The following is a description of a gene set: studied in species Homo sapiens Human Gene Set: MIR6838_5P from publication Chen Y, Wang X (PMID 31504780) Genes predicted to be targets of miRBase v22 microRNA hsa-miR-6838-5p in miRDB v6.0 with MirTarget v4 prediction scores > 80 (high confidence targets)., and this is the list of marker genes: KRTAP4-6, MAP3K13, UNC5D, MED26, SLC13A3, KCNG4, KIF23 (kinesin family member 23), DCP1A, DDX3X, LITAF, ZC2HC1A, VPS33B (VPS33B late endosome and lysosome associated), BCL2L2, RPS6KA3, CPD, SUCO, CAPRIN1, NHLRC2, LYPLA2, SEMA3A, ZBTB39, IPO7, GALNT13, ZCCHC3, SYT3, IVNS1ABP, OGT, CSRNP1, TLK1, TLL1, ZFHX3, FAM91A1, LURAP1L, RS1, COBLL1, PPT2, AGO1, ARIH1, ENAH, HOXA10, MYEF2, APLN, ROCK2, RPS6KA6, MAMSTR, DDX3Y, WEE1, SLC39A10, P3H2, MFN2 (NCBI Gene Id 9927), SPRED1, SEH1L, TAB3, SSTR3 (NCBI Gene Id 6753), ZNRF3, ZNHIT6, CPEB3, SPTBN2, RAB9A, SPRYD3, SOX6, C1QL3, CDK17, IGF2R, MEX3C, GCC2, MNT, ZNF449, ZFHX4, GLS2, TMC7, TENM2, STK33, PARVA, NRN1, CSDE1, SCN8A, PLAG1, RFX3, PAFAH1B1, RSPO3, EDA, MASP1, GNAT1, NSMF, HERC6, ELL (NCBI Gene Id 84205), NUFIP2, PHF19, INSR, SRPRA, ABHD2, TUBA4A, MYO5A, SLC2A14, ZSCAN31, PTPN3, CD47, AK4, SCOC, WNT7A, JARID2, SLC20A2, SMIM13, NR2C2, RBM6, RICTOR, CPSF7, FBXL20, TCAIM, DMPK, CASK, KRTAP11-1, GPR63, ATG13, FAM89A, RAB11FIP2, USP44, DEPDC4, DYRK1B, USP31, PLXNC1, KANK1, CFAP45, LRIG1, PPM1E, RECK, TMEM268, SNX16, AMOT, SNRPB2, UBFD1, JPH3, ANKRD46, CDCA4, SREK1, CDC42SE2, ABTB2, SNTB2 (syntrophin beta 2), CCNJL (NCBI Gene Id 79616), CLUH (NCBI Gene Id 23277), OMG, TNFSF13B, MKX, LAMC1, ARMCX2, ISLR, SLC36A1, KIF5C, PRDM4, IKBKB, ARL3, ATF6, RNF217, SLC11A2, PAPPA, ARHGAP12 (NCBI Gene Id 94134), DENND1B, G2E3, IFT74, ARHGAP32, SLC35G1 (solute carrier family 35 member G1), CACNA2D1, KCNN4, PTH, MOB3B, PAG1, ATXN7L3, TMCC1, NCS1, PPP6R3, MAP7, MYLK, CPEB2, SEMA5B, TFAP2A, PIP4P1 (phosphatidylinositol-4,5-bisphosphate 4-phosphatase 1), STXBP3, SYNJ1, SYNRG, MEOX2, ZBTB34, DRD1, HTR2A, MYT1L, CCNT1, PTPRR, SALL1, NF1, EPHB2, RASGEF1B, LRIG2, SHOC2, FAM133B, GPATCH8, RREB1, SOCS6, HEPHL1 (hephaestin like 1), RASSF8, BTG2, HSPG2, CCNE1, CDK5R1, FBXW7, HELZ, GPN1, USP3, UBE4A, PPP1R11 (NCBI Gene Id 9160), EPHA7, CD2AP, CYP2S1, CD80, AVL9, ANKUB1, SAMD10, EXOC3L2, PLPP1, ZMAT3, NRBP1, MTFR1L, TTC14, ACVR2B, POU2F1, DYNC1LI2, ARFGAP2, AHCYL2, STRADB, CACNA1E, ASH1L, CYP26B1, ZC3H13, CLCN4, SUZ12, AKT3, NOB1, PLXNA4, SGK1, FGF2, PEDS1-UBE2V1, PPM1A, TARBP2, BCL11B, HIGD1A, RELN, ZNF622 (zinc finger protein 622), CACUL1, PLRG1, AMOTL1, C2orf42, CLOCK, SLC9A6, LAMP3, ANO3, EZH1, PCMT1, MAP2K1, FASN (fatty acid synthase), CMPK1, TGIF2, TMEM154, BZW1, WNK3, FOXK1, CEP55, CDC27, DNAJB4 (DnaJ heat shock protein family (Hsp40) member B4), KIF3B, ZNRF2, TRIM66, CDC37L1, MOB4, MYO5B, HSPA4L (NCBI Gene Id 22824), AMMECR1, GFAP, WWC1, RBM24, HIPK2, FGF7, ST7L, ZCCHC2, TGFBR3, SERBP1, RASEF, ARHGDIA, SLC25A37, KDSR, VTI1B, HMGA1, XPO7, ATXN7L1, TMEM178B, ZNF691, SYDE2, RFK, BAG4, CD3E, SYPL1, TMEM183A, UROS, RBBP6, CDC25A, TRANK1, TSC22D2, NFATC3, SLC12A2, HTR4, SUSD6, KCTD8, EYA1, CUX1, TBL1XR1, SAV1, TMEM199, BTRC, GSTCD, STOX2, TRAM1, LRP2, DIXDC1, ADRB2, SLC6A11, RNF144B, MYB, PDZD8, LATS1, HMBOX1, ACOX1, ATXN1L, QKI, PEX13, C12orf76, LDLRAD2, CCND2, KCNK10, SON, WNT3A, AMER1, YWHAH, SSR1, CCDC88C, CAPZA2, ABCF3, AGO4, PELI2 (NCBI Gene Id 93480), G0S2, UTP25, CREBRF, UBE4B, PCDH9, NAPG, GABARAPL1, SIRT4, COL12A1, TMEM135, LUZP1, C1orf21, NAV1, PISD, COP1, DLL1, SEL1L3, GGA3, ADGRL1, MYBL1, UNC13A, YTHDC1, CNOT6L, RET, USP25, TFCP2L1, VEGFA (NCBI Gene Id 7422), CHAC1, SPTLC1, ATXN7L3B, ENSG00000275993, IARS1, TBP (TATA-box binding protein), GAREM1, RARB, NECTIN1, CMC4, CHUK, NSG1, VPS4A, ACVR2A, ILDR2, WIPI2, CHEK1, CXCR5, SLC4A4, PABIR2, KIF1B, PNPLA6, WBP11, RGMA, PPP2R1B (protein phosphatase 2 scaffold subunit Abeta), RUNX1T1, USP42, ETNK1, PTPRD, NAA25, CASR, SUMO3, CBX6, STXBP5, UBN2, RETREG2, DMTF1, RBM12, PDE3B, ATXN2, ACTR2, CDK8, GHR, GRM7, MKNK1, FGFR1, ANKS1A, SETD3, NUP50, ST8SIA3 (ST8 alpha-N-acetyl-neuraminide alpha-2,8-sialyltransferase 3), SIK1, CHPT1, EPC1, SMURF1, PDK4, SEC24A, MAP3K9, DCLK1, ADAMTS3 (NCBI Gene Id 9508), UBQLNL, MCU, RAB30, BTAF1, FAM110C, UBE2Q1, FBXO21, FAM135A, PCDH17, ARHGAP20, KIF5B, NOS1, RBPJ, PAFAH1B2, ATG9A, MAN2A2, ZMYM2, USP15, KLHL2, SESN1, SOBP, SALL4, ATXN7L2, TRABD2B, LRRN3, ERC2, IPPK, DPY19L4, CBX4, ZBTB46, FLT3, MIDEAS, PTPN4, CEP85L, CBX2, KCNJ2, N4BP1, TMEM100, CHD2, GATAD2A, SYT4, PIAS2, PRRC2C, SLIT2, AXIN2, TBPL1, RORA, GALNT7, RUNDC3B, CCND1, FAM81A, FERMT2, PDIA6, KIF21A, ARL2, TMEM245, SH3GL2, RNF10, E2F3, DESI1, OTX1, SEPTIN2, MTMR3, SMAD7, RAD50, SIPA1L2, LSM11, EGLN1, CC2D1B, CARM1, NRP2, UNC80, RAB9B, ARMH4, COPS7B, CCDC6, UBE2V1, LGR5, ZDHHC15, LRP6, ZNF367, CHIC1, PIP4P2, ATG14, SKI, ABL2, SEMA6D, ELAC1, CYB561A3, TNRC6B, LRRK1, OOEP, MGAT4A, LARGE2, DENND2C, PTCH1, PIK3R1, HECTD1, RAD23B, ZBTB44